The following is a description of a gene set: Any process that increases the rate, frequency, or extent of dendritic spine morphogenesis, the process in which the anatomical structures of a dendritic spine are generated and organized. A dendritic spine is a protrusion from a dendrite and a specialized subcellular compartment involved in synaptic transmission. Mouse Gene Set: GOBP_POSITIVE_REGULATION_OF_DENDRITIC_SPINE_MORPHOGENESIS studied in species Mus musculus, and this is the list of marker genes: Il1rapl1, Dnm1l, Actr2, Lrp8, Caprin1, Cask, Pafah1b1, Cux2, Afdn, Slc30a1, Stau2, Reln, Caprin2, Opa1, Dhx36, Xlr3b, Kalrn, Marcks, Tiam1, Ephb2, Bhlhb9, Dbn1, Itpka, Dbnl, Camk2b, Actr3, Mfn1, Mfn2, Ptprd, Baiap2, Eef2k, Pak3